The following is a description of a gene set: The progression of an axon over time. Covers axonogenesis (de novo generation of an axon) and axon regeneration (regrowth), as well as processes pertaining to the progression of the axon over time (fasciculation and defasciculation). studied in species Homo sapiens Human Gene Set: GOBP_AXON_DEVELOPMENT, and this is the list of marker genes: APBB2, TTC8, AP5Z1, TBC1D24, BMPR1B, ATP8A2, ENAH, THY1, SEMA3B, SEMA4B (NCBI Gene Id 56962), SRF, S100A6, TNN, ANK3, EPHA8, VANGL2, SPG11, MATN2, OLIG2, VASP, FSTL4, SLIT3, NTRK3, TRIO, KALRN (NCBI Gene Id 8997), NOVA2, NOTCH3, ISLR2, ANAPC2, DHFR, PLXNB2, NRXN1, NR4A3, TSPAN2, UNC5B, PAK2, NELL2, ARTN, TOP2B (DNA topoisomerase II beta), FOLR1, CTNNA2, DRGX, SYNGAP1, MIR431, SIN3A, TIAM2, KIF5C, CNTF, PRKCA, PPP3CB, NTRK1, EPHA4, EFNA4, MACF1, MTR, ARX, NOG, STXBP1, GLI3, PTPRJ, LLGL1, SEMA3C, VCL, EDN2, NCAM1, EFNA3 (NCBI Gene Id 1944), DIP2B, SEMA4G (NCBI Gene Id 57715), PTPRZ1, VASH2, GRM7, PARD6B, CSF1R, RAB8A, FLRT3, TAOK2, TCTN1, EDNRA, PTPRF, DHFRP1, INPP5F, SPAST, LAMA2, USP33, OLFM1, CNTN2, MMP2, PLPPR4, BCL11B, ABLIM1, NFASC, APLP2, OTX2, FEZ1, ITGB1, NDN, CCKAR, SEMA3G, TNFRSF12A, PRDM8, CAMSAP2, CREB1, NUMBL, SPTBN4, CDK5R1, CDH1, KIF21A, EFNB1, COBL, B4GALT5, LYPLA2, BORCS7, PSEN1, NPR2, NR4A2, CHODL, SPART, EFNB2, NDEL1, SMAD4, EDN1, NREP, APOE, LGR6, RYK, ADCY1, NEFH, BRAF, RGMA, GRN, AMIGO1, CTNNA1, CNTN6, RTN4RL2, TNC, ATOH1, KLF7 (KLF transcription factor 7), CRTAC1, NTN1, LIMK1, NKX2-1, NTNG1 (NCBI Gene Id 22854), PTN, MAP6, ACTBL2, FLRT2, SVBP, SLIT2, PTPRH, NTNG2, TRIM32, SLITRK3, APBB1, HDAC6, TRAK2, NEUROD2, ARHGEF40, AUTS2, POU4F2, DVL1, EFNA1, NEO1, NUMB, RNF6, NRXN3, ULK2, KLF4, RELN, SLITRK4 (NCBI Gene Id 139065), FGFR2, SEMA6C, NR2E1, CD2AP, TBCE, TSKU, NGFR, BCL11A, HOXA2, EPHA5, CELSR3 (NCBI Gene Id 1951), VAX1, MAP1S, NRP1, ZPR1, LHX9, RAB3A, GATA3, RTN4RL1, SLC25A46, FBXO45, C12orf57, LRIG2, SEMA3F, WNT7A, FYN (NCBI Gene Id 2534), MARK2, JAK2, NPTX1, PLEKHG4B, SEMA4F, PLP1, ZFYVE27, CNTNAP1, RET, ROBO3, PTPRO, FEZF2, FEZF1, DCLK1, SEMA6D, TBR1, TRPC5, SHH, TNR, RPL24, DCC, POU3F2, CDH4, SPP1 (NCBI Gene Id 6696), USP9X, ARHGEF28, SLITRK5, KIAA0319, CHRNB2, NEUROD4, KREMEN1, PICALM, ROBO2, LHX3, UST, DDR1, SLITRK6, FLOT1, EVX1, PCDHAC2, SIPA1L1, NGF, PLXNA3, CNP, FOXD1, PTK2, CDKL5, EFNA2, ACTL8, GAP43, DPYSL5, CCK, APP, CASP3, YTHDF1, MAP1A (microtubule associated protein 1A), L1CAM, KIAA1755, CYFIP1, DLX5, DAB1, DISC1, EPHA3, IFRD1, TUBB2B, NOTCH1, MAPK8IP3, TRPV2, EPHB6, ADCY10, GBX1, GDF7, CXCL12, BRSK1, DAG1, LPAR3, NTN4 (netrin 4), EGR2, POU4F3, B3GNT2, B4GALT6, SCN11A, RTN4, TWF2, KIF5A, CDK5R2, NEXN, FGF13, TRAK1, FZD3, WDR47, MAP7D2, CTTN, SLITRK1, LRP4, BOC, ALCAM, UNC5D, AFG3L2, MCF2, ZDHHC17 (NCBI Gene Id 23390), FOXG1, NFIB, SLITRK2, NIN, UNC5C, EPHA7, APOA4, OPHN1, NOTCH2, NEFL, PAFAH1B1, MAP2K2, POTEKP, MEGF8, PHOX2B, PAK3, FN1, KIF5B, BMP7, RAC3, GDI1, SCARF1, SEMA3E, BHLHE23, CDKL3, ANOS1 (NCBI Gene Id 3730), POTEI, NKX2-8, DOCK7, RTCA, LHX4, EFNB3, RAB21, SLC9A6, TNFRSF21, PTEN, PLA2G10, APLP1, COL25A1, ISL1, WNT7B, FOXB1, MAG, PLXNB1, NEUROG3, RUFY3, EDN3, VAX2, BARHL2, PAX6, IST1, BHLHE22, HMCN2, WNT3, CYFIP2, PLEKHG4, SIAH1, POU4F1, SEMA5A, MYH10, B4GAT1, LMO4, SLIT1, TSPO, SZT2, MAP2K1, PTCH1, VEGFA, CERS2, NDP, OR10A4, MAP2, OLIG3, DSCAML1, PARD3, CNR1, PLXNC1, NRDC, DSCAM, MYPN, SEMA7A, SHOX2, SMURF1, STK24, RAPH1, BHLHA15, EPHB1, ARK2C, EVL, NEUROD1, SEMA4C, SEMA6B, BAIAP2, CNTN4, ADGRB1, SEMA6A, GDNF, RTN4R, NPTN, UNC5A, EPHA10, NCAM2, PLXNB3, POTEJ, SEMA5B, MAP1B, LHX2, PITPNA, BSG (basigin (Ok blood group)), EPHB2, METRN, ATL1, STMN1, NEUROG1, ITGA4 (NCBI Gene Id 3676), PLXNA4, SEMA4A, CRABP2, UCHL1, LHX1, FEZ2, GFRA3, GSK3B, ABL1, TTL, GPM6B, CDH11, ARHGAP4, TGFB2, POTEF, LRRC4C, KIFC2, CNTN1, PLXND1, CLASP2, NEUROG2, RPS6KA5, NRCAM, EXT1, MT3, TIAM1, MIR221 (microRNA 221), RND2, PTK7, DNM2, ACTB, ROBO1, LMX1A (NCBI Gene Id 4009), CHL1, BDNF, PUM2, GLI2, CHN1, ADARB1, GOLGA4, NECTIN1, PRKG1, ULK1, ACTG1, KIF13B, ADAM17, C9orf72, OLIG1, TUBB3, EPHA6, MGARP, MIR222, APOD, SKIL, NRP2, ECE1, ISL2, NLGN3, BMPR2, CDK5, PGRMC1, BRSK2, STK25, KIFBP, NTRK2, CRPPA, SMO, PTPN11, JUN, PAK1, EPHB3, PTPRM, PAX2, FIGNL2, DRAXIN, LAMB2, NKX6-1, SEMA4D, MAPT, POTEE, SCN1B, GBX2, RAC1, ERBB2, NTN3, MYCBP2, PRICKLE1, PRKCQ, NEUROD6, WNT5A, ZEB2, ETV1, STK11, BCL2, MAP3K13, ATOH7, EFNA5, RAB10, ROBO4, SSNA1, SHTN1, KEL, MYOT, LGI1, EMB, TRIM46, ARHGEF25, WNT3A, IGSF9, SOS1, PTPRS, SEMA3A, NMNAT2, S100B, FGF8, SEMA3D, SPG21, ARHGAP35, DRD2, CNTN5, ADNP, XK, PALLD